Given this list of marker genes Exosc1, Exosc3, Exosc9, Zfc3h1, Dis3, Exosc6, Gtpbp1, Mphosph6, Exosc10, Mtrex (Mtr4 exosome RNA helicase), Exosc4, Dis3l, Wdr74, Exosc5, Exosc7, Exosc2, Zfp36, Nvl, C1d (C1D nuclear receptor co-repressor), Carhsp1, Exosc8, here is a description of the gene set: species: Mus musculus Mouse Gene Set: GOCC_EXOSOME_RNASE_COMPLEX A ribonuclease complex that has 3-prime to 5-prime exoribonuclease activity and possibly endoribonuclease activity, producing 5-prime-phosphomonoesters. Participates in a multitude of cellular RNA processing and degradation events preventing nuclear export and/or translation of aberrant RNAs. Restricted to processing linear and circular single-stranded RNAs (ssRNA) only. RNAs with complex secondary structures may have to be unwound or pre-processed by co-factors prior to entering the complex, esp if the 3-prime end is structured.